The following is a description of a gene set: Analysis of mobilized peripheral blood CD34+ cells from a healthy volunteer under erythroid differentiation conditions with and without stimulation to the BMP or Wnt signaling pathways. For erythroid differentiation, expanded CD34+ cells were placed in Stemspan SFEM medium supplemented with 2% pen/strep, 20ng/ml SCF, 1U/ml Epo, 5ng/ml IL3, 2uM dexamethasone, and 1uM beta-estradiol. Arrays were performed 2 hours after addition of cytokines. For signaling pathway stimulation, cells were exposed to 0.5uM BIO (a GSK3 inhibitor) for Wnt pathway activation, 25ng/ml rhBMP4 for BMP pathway activation, or vehicle control for 2 hours. Three biological replicates were performed per treatment group. We used microarrays to detail the global program of gene expression changes after Wnt or BMP pathway stimulation in human CD34+ hematopoietic progenitors under erythroid differentiation conditions. from publication Trompouki E, Bowman TV, Lawton LN, Fan ZP, Wu DC, DiBiase A, Martin CS, Cech JN, Sessa AK, Leblanc JL, Li P, Durand EM, Mosimann C, Heffner GC, Daley GQ, Paulson RF, Young RA, Zon LI (PMID 22036566) Human Gene Set: GSE26351_WNT_VS_BMP_PATHWAY_STIM_HEMATOPOIETIC_PROGENITORS_DN studied in species Homo sapiens Genes down-regulated in CD34+ cells treated with GSK-3 Inhibitor IX (BIO) versus those stimulated by BMP4., and this is the list of marker genes: GSDME, SMCR8, MAP2K3, MOSMO, MADD, PSMA8, ZNF862 (zinc finger protein 862), KIFBP (kinesin family binding protein), POU2F2, ZNF622, PUM2, GAN, BICRAL, TMED5, TIMM21, KLHL24, PPM1E, ENG, ZRSR2, CDC42EP4, LUZP1, SLFN13, NAT8L, B4GALT6 (NCBI Gene Id 9331), XPO7 (NCBI Gene Id 23039), ZDHHC18, MTRES1, COMMD9, E4F1, RNF216, AAGAB, USP19 (NCBI Gene Id 10869), FUT11, ALDH7A1, LAP3, SHISA5, KCTD18, KIF1B, CYP2R1, ZBTB11-AS1, RAB35, TFB2M, ABHD17C, CBX7, AGPS, RRAGC, IL6ST, GGNBP2, HIVEP3, ELP2 (NCBI Gene Id 55250), EDEM3, REPS1, WLS, GNA13, ELP3, DMAP1, ALKBH5, PIGP, AAMDC, CCDC186, TMEM243, PCMTD1, SLC25A53, ANKRD50, ZSWIM3, PPP2CA, DNAJC7 (NCBI Gene Id 7266), ATP6V1D (NCBI Gene Id 51382), ENDOG, CMYA5, EMSY, PHF20, GHDC, SNX14, EED, TTC39B, STRIP1, TRIAP1, TIAL1, CDK5R1, YPEL2, TUBGCP6, CR1L, QSER1, MAP3K5, MAEA, RGL2, PCM1, SLC38A9 (solute carrier family 38 member 9), STX2, PHIP, EXOC6B, MAP3K4 (NCBI Gene Id 4216), SLC22A17, RWDD3, ARVCF, PRKCE, MYO1E, PIGX (phosphatidylinositol glycan anchor biosynthesis class X), MESD, GAS2L1, MARCHF5, RABEP2, PCP4, C14orf119, CTNND1, OGFOD3, RAB27A, METTL23 (NCBI Gene Id 124512), UBR1, CLUAP1, MON1B, ASPH, MTF1, DOLK, HK3, TOE1, ANKS3, DDIT4, TWF1, RSRC2, KCTD3, NMD3, UBA5, ODR4, FAM3C, ARMC7, BAZ1B (bromodomain adjacent to zinc finger domain 1B), ITGB3BP, YTHDF1, YTHDF2, NRROS, ACCS, TATDN1, RNF121, SPAST, BCKDHB, PLBD2, TMEM267 (NCBI Gene Id 64417), PRRC1, FARP1, TRUB1, NKRF, FZD8 (frizzled class receptor 8), TMEM68, MYMK (myomaker, myoblast fusion factor), PDZD8, LUC7L2, RRP1B, TBL2, IRS2, DGAT1, TMOD1, SFR1, RMND5B, MBTD1, PIK3R4, PRUNE2, TSSC4, TMEM65, TEF, ZNF32, MAPRE2, STEEP1, LMF1, PORCN, ALG14, PXDC1, RNF115, FGF13, UBLCP1 (NCBI Gene Id 134510), TMF1, MMS19, IFTAP, XYLB, GSDMD, SEC22A, PCMT1 (NCBI Gene Id 5110), ACVR2A, ITPKB, SNRNP48, TNNT1, RAB5IF, ZNF513, LTF, GKAP1, SOCS6, DYNLT3, PER3, TRIM8, C19orf12, TTC27, CDK10, XPNPEP3, IKBKG, CST7, HGSNAT, ZBTB48, AKAP13, MMP9